Given this list of marker genes Cyp4a31, Slc26a6, Anxa1, Ces1h, Nr0b2, Hrh3, Slc10a1, Rbp1, Got2, Slc25a20, Nherf1, Kiss1r, Slc22a8, Ces1g, Pla2g2c, Rps6kb1, Slc27a1, Fabp1, Abcc1, Lypla1, Slc22a1, Drd2, Ace, Aqp9, Aqp8, Acsl3, Stard10, Slco2b1, Proca1, Abcc4 (ATP-binding cassette, sub-family C member 4), Nr1h4, Lyn, Abcb4, Nmb (neuromedin B), Fabp7, Ucp2, Slco1a6, Apoe, Slco3a1, Slco1b2, Pla2g2a, Ptges, Pla2r1, Pmp2, Abcd2, Ces1b, Slc22a22, Slco1a4, Drd4, Abcg2, Tnfrsf11a, Slc10a5, Pla2g10, Slco1c1, Akt1, P2ry2, Crabp2, Cyp7a1, Slc10a2, Lep, Slc22a6, Slc16a3, Slc16a9, Slc10a4-ps, Emb, Akt2, Slco1a7, Abcc3, Hnf1a, Ces1a, Lhcgr, Crot, Rbp2, Cyp4a10, Pla2g2d, Slc6a12, Mpc2 (NCBI Gene Id 72048), Kcnj8, Plin2, Slc6a8, Fgf15, Slc43a3, Slc10a4, Slc16a1, Slc5a6, Slc16a11, Slco1a1, Il1b, Slc17a5, Abcc2, Slc27a5, Slc10a6, Sstr4, Abcb11 (NCBI Gene Id 27413), Pnpla8, Fabp6, Slc22a13, Slc27a2, Tnfsf11, Pla2g3, Pla2g4a, Crabp1, Pla2g6, Erfe, Mpc1 (NCBI Gene Id 70697), Cldn2, Fabp4, Ces1c, Slc25a17, Slc27a4, Avpr1b, Spx, Ceacam1, Abcd4, Syk, Mif, Eprs1, Slc22a3 (NCBI Gene Id 20519), Ces1d, Casr, Slc26a7, Slc27a6, Acsl6, Slco4a1, Slco1a5, Pparg, Tmem135, Ceacam2, Slc51b, Pla2g12b, Slc16a8, Myc, Hrh2, Oxt, Cyp4a32, Pla2g2f (phospholipase A2, group IIF), Ppard, Ntsr1, Slc51a, Acsl4, Slc22a7, Acsl5 (NCBI Gene Id 71879), Ces1e, Repin1, Acsl1, Mapk9, Fabp9, Fabp12, Rbp7 (NCBI Gene Id 80531), Mip, Map2k6, Slc27a3, Abcd1, Ces1f, Drd3, Slco1a8, Slc16a12, Tnf (tumor necrosis factor), Slc6a13, Pla2g4f, Tspo2, Abcd3, Bdkrb2, Oc90, Atp8b1, Nmur2 (neuromedin U receptor 2), Fis1, Cd36, Nos2, Pla2g2e, Slc10a7, Fabp3, Agtr2, Slc10a3, Slc22a2, Irs2, Slc6a11, Thbs1, Pla2g1b, Slc16a7, Slc2a1, Slc5a8, Il1a, P2rx7, Slco2a1, Acacb, Cpt1b, Edn1, Fabp5, Cpt2, Pla2g12a, Pla2g5, Mfsd2a, Ptgs2, Slc5a12, Atp5pf, Fabp2, here is a description of the gene set: species: Mus musculus The directed movement of monocarboxylic acids into, out of or within a cell, or between cells, by means of some agent such as a transporter or pore. Mouse Gene Set: GOBP_MONOCARBOXYLIC_ACID_TRANSPORT